Given this list of marker genes TNKS2, RTKN2, TMC4, RILPL2, STRN3, TXNL4B, SMYD5, WDR44, SLC39A9, ZCCHC12, MIEF1, RAB42, SAMD4A, PLEKHF1, TPPP3, TRPC5, PSMB5, RNF19B, SFRP1, TREM1, SCO1, P2RY13, WDR82, PPME1, POU5F2, PIAS1, TRIM69, PTGS2, PTGFRN, PHF6, TNFRSF21, STAT2, RAB13, TWSG1, SHISA6, VWA5A, PRKACB, PCMTD1, SLC1A5, TMPRSS11D, RLBP1, TMEM214, WDR36, POU3F4, PON1, SLC25A18, PLCE1, SLC7A5 (NCBI Gene Id 8140), VPS11, P2RX1, PSMC5, YPEL2, RIMKLB, RBMS1, ST8SIA6, ZFYVE26, RNF152, PRAM1, SELPLG, TTYH3, XPOT, TAX1BP1, WBP4, TMEM132B (transmembrane protein 132B), USP11, PSMC4, RASA4, STARD3NL, PDIA3, RNF214, PLCB3, ZPBP, SLC27A4, XAB2, TCTN3, TOB2, TDRD5, PPP1R16B, PFKP, SEPTIN1, MSRB1, PPP2R2A, STON2, RHOBTB1, TTF1, SMPX, VASH1, QRSL1, SHH, SMG5, SORBS2, SCRT2, DESI2, PRMT6, SSTR4, TAAR6, ODAD4, PGAM5, SLC46A3, USH2A, PRPS1L1, TLR3, STRADA, UBC, P2RY2, FAM156A, PRDM1, SEC23B, SEMA5A, TNNI1, SNAP25, SMURF1, PLA2G12A, SLC43A1, TAS1R1, TENT4A, SIX3, STOML2, SH2D6, UBE2DNL, SERPINA5, RECQL5, PRAF2, PAPOLA, SPATA19 (NCBI Gene Id 219938), TMSB15A, PTK6, TEKT3, SNPH, SEMA4A, RAB20, TRMT2A, ZBTB20, PIK3C2A, PTGFR, TUBD1, USP12, TRAPPC3, RNASEL, PRELID1, RNF144A, RBM43, VWF, SYT17, SLC22A14, ZC3HC1, PRKD1, PHOX2B, PDE10A, SALL3, TCERG1, RPRM, TRIM21, P2RY12, TDRD7, PKIA, SNX3, UPP1, STX17, VPS8, PTDSS1, PPP1R9A, here is a description of the gene set: Genes down-regulated in CD4 T cells activated by anti-CD3 and anti-CD28: IL-12 (2h) versus TGFB1 and IL-12 (2h). Human Gene Set: GSE2770_IL12_VS_TGFB_AND_IL12_TREATED_ACT_CD4_TCELL_2H_DN Th1 and Th2 cells arise from a common precursor cell in response to triggering through the TCR and cytokine receptors for IL-12 or IL-4. This leads to activation of complex signaling pathways, which are not known in detail. Disturbances in the balance between type 1 and type 2 responses can lead to certain immune-mediated diseases. Thus, it is important to understand how Th1 and Th2 cells are generated. To clarify the mechanisms as to how IL-12 and IL-4 induce Th1 and Th2 differentiation and how TGF-beta can inhibit this process, we have used oligonucleotide arrays to examine the early polarization of Th1 and Th2 cells in the presence and absence of TGF-beta after 0, 2, 6 and 48 hours of polarization. studied in species Homo sapiens from publication Lund R, Aittokallio T, Nevalainen O, Lahesmaa R (PMID 14607935)